Given this list of marker genes Sirt6, Art2a, Art1, Arf4, Art2b, Art5, Art4, Art3, here is a description of the gene set: studied in species Mus musculus Catalysis of the reaction: L-arginyl- + NAD+ = H+ + (ADP-D-ribosyl)-L-arginyl- + nicotinamide. Mouse Gene Set: GOMF_NADPLUS_PROTEIN_ARGININE_ADP_RIBOSYLTRANSFERASE_ACTIVITY